Given this list of marker genes Myog, Actn3, Rps6kb1 (ribosomal protein S6 kinase, polypeptide 1), Mstn, Gsn, Asb2, Cflar, here is a description of the gene set: studied in species Mus musculus Mouse Gene Set: GOBP_STRIATED_MUSCLE_ATROPHY A process, occurring in striated muscle, that is characterized by a decrease in protein content, fiber diameter, force production and fatigue resistance in response to different conditions such as starvation, aging and disuse.